Given this list of marker genes SAP30, FDPS, CD86, RELA, NEDD9, OXCT1, RPS19, ATF3, ATP11C, PRMT6, GZMA, PPP6R2, EEF1D, NUMB, THAP2, SELENOT, NT5C3A, KIF1C, RND3, ABCG4, NCK2, SRP68, LARP7, EIF2S3, EMC6, FAM184B, CSF3R, NAA20, MOB1B, SNN, MAFF, EXOC4, LAMC3, TIGD5 (tigger transposable element derived 5), NAXE, SLC4A2, ST3GAL5, ITPRID2, CAMKK2, DBNL (drebrin like), S100A13, AMHR2, GADD45B, PTRHD1, ARMCX3, SND1, MSC, BATF2, MYOC (NCBI Gene Id 4653), EVA1A, MPP4, ZBTB18, ANKRD13A, ANAPC13, IL1B, LSS, HACD2, ASGR2, SF3A2, SDHC, RNASE2, KLF6, CENPM, LHX9, TEX264 (testis expressed 264, ER-phagy receptor), CDX2, CALML4, REEP3, FMC1, DLL1, GRIA2, IFNAR1, DEPDC7, DOCK1, ELF5, DENR, MID2, SERPINB2, PDIA6, ACO2, PLCL2, RHOH, SLC41A2, FOXD3, YPEL1, RNF38, TMEM120B, PCLAF, STX1A, MOB3B, TOP1, CCNJ, UTF1, SLC12A4, CALML3, FXYD5, AP1G2, GPR3 (G protein-coupled receptor 3), LSM4, ERAL1, SVEP1, IL6ST, MB, UPP1, ASB11, ECE1 (NCBI Gene Id 1889), NDUFA11, PLTP, COTL1, GALNT3, SREBF2, AGO2, IL4I1, PLEKHF1, CD93, LCP2, ZNF207, RARG, PTGIS, NR1H4, ARF6, DPP7, HS3ST3B1, SRGAP3, ANXA3, ABCG2, COX6B1, TREM2, ATP5PB (ATP synthase peripheral stalk-membrane subunit b), TRIB1, UQCR11, FUOM, ZNF318, RPLP1, EEF1AKMT1, CCDC86, WDR86, KLHL11, EPB41L2, TRAM1, SAMM50, PLAAT3 (NCBI Gene Id 11145), SNX4, STARD4, UBE2C, KANK3, FKBP5, PPP6C, STK40, HMGN3, RNPEPL1, LAPTM5, UBE2H, LTA, TBC1D13, POLR3D, SERPINB1, TRAPPC6A, SEMA5A, STXBP6, GMPPB, GM2A, NSMCE2, LAPTM4B, PUF60, AP1M1, GHRHR, CELA2A, UFM1, MYO5A, MEF2A, ARHGAP6, ZNF385A, ITCH, EHD2, FKBP11, SLC17A1, PSME1, SVBP, MEMO1, HNRNPLL, TUBB2A, TTL, IGHG1, TPK1, SLC25A3, UXT (ubiquitously expressed prefoldin like chaperone), PHYHIPL, MELK, KCNN4, NR2F6, MLC1, ARHGEF7, ANXA11 (NCBI Gene Id 311), OXT, CD74, TSPAN15, NAP1L1, RAB8B (NCBI Gene Id 51762), COX4I1, here is a description of the gene set: mouse primary BMDCs were stimulated with tlr ligands and gene expression changes were profiled on Affymetrix arrays from publication Amit I, Garber M, Chevrier N, Leite AP, Donner Y, Eisenhaure T, Guttman M, Grenier JK, Li W, Zuk O, Schubert LA, Birditt B, Shay T, Goren A, Zhang X, Smith Z, Deering R, McDonald RC, Cabili M, Bernstein BE, Rinn JL, Meissner A, Root DE, Hacohen N, Regev A (PMID 19729616) Human Gene Set: GSE17721_4_VS_24H_GARDIQUIMOD_BMDC_UP studied in species Homo sapiens Genes up-regulated in comparison of dendritic cells (DC) stimulated with Gardiquimod (TLR7 agonist) at 4 h versus those stimulated with Gardiquimod (TLR7 agonist) at 24 h.